Given this list of marker genes FGF1, FGF9, FGF16, FGF18 (NCBI Gene Id 8817), FGF20, FGF23, FGF2, FGF8, FGF5, FGF4, FGFR3, PLCG1, FGF17, here is a description of the gene set: Phospholipase C-gamma (PLC-gamma) is a substrate of the fibroblast growth factor receptor (FGFR) and other receptors with tyrosine kinase activity. It is known that the src homology region 2 (SH2 domain) of PLC-gamma and of other signaling molecules (such as GTPase-activating protein and phosphatidylinositol 3-kinase-associated p85) direct their binding toward autophosphorylated tyrosine residues of the FGFR. Recruitment of PLC-gamma results in its phosphorylation and activation by the receptor. Activated PLC-gamma hydrolyzes phosphatidyl inositol P2 to form the second messengers diacylglycerol (DAG) and InsP3, which stimulate calcium release and activation of calcium/calmodulin dependent kinases.<br> part of: Downstream signaling of activated FGFR3 Reactome Pathway: Phospholipase C-mediated cascade; FGFR3 species: Homo sapiens